Given this list of marker genes APP, MSTN, NCSTN, PSENEN, PSEN2, NFKB2, BACE1, SIRT1, MAPT, PSEN1, NFKB1, here is a description of the gene set: Inclusion body myositis Human Gene Set: WP_INCLUSION_BODY_MYOSITIS studied in species Homo sapiens